Given this list of marker genes GRB2, BRAF, PDGFB, PDGFA, MAPK3, SOS1, KRAS, NRAS, HRAS, MAP2K2, SOS2, ARAF, PDGFRB, MAP2K1, MAPK1, RAF1, PDGFRA, here is a description of the gene set: species: Homo sapiens Human Gene Set: KEGG_MEDICUS_REFERENCE_PDGF_PDGFR_RAS_ERK_SIGNALING_PATHWAY Pathway Definition from KEGG: PDGF -> PDGFR -> GRB2 -> SOS -> RAS -> RAF -> MEK -> ERK PDGF-PDGFR-RAS-ERK signaling pathway. Pathway ID: N00015. Pathway type: Reference. Pathway class: nt06273 Glioma.